Given this list of marker genes Incenp, Rcc2, Cdca8, Ccnb1-ps, Ccnb1, Hnrnpu, Kat5, Cenpe, Sirt2, Becn1, Kat2b, Birc5, Aurkb, here is a description of the gene set: Any process that activates or increases the frequency, rate or extent of the attachment of spindle microtubules to the kinetochore. Mouse Gene Set: GOBP_POSITIVE_REGULATION_OF_ATTACHMENT_OF_SPINDLE_MICROTUBULES_TO_KINETOCHORE species: Mus musculus